Given this list of marker genes KRTDAP, SFTPB, KLK7, CKAP4, KLK5, SFTA3, TMEM63B, NAPSA, ABCA12, LAMP3, SMPD1, SFTPA1, SFTPC, RAB7A, ABCA3, CTSH, SFTPA2, SPINK5, here is a description of the gene set: A membrane-bounded organelle, specialized for the storage and secretion of various substances (surfactant phospholipids, glycoproteins and acid phosphates) which are arranged in the form of tightly packed, concentric, membrane sheets or lamellae. Has some similar properties to, but is distinct from, a lysosome. Human Gene Set: GOCC_LAMELLAR_BODY species: Homo sapiens